Given this list of marker genes CNOT9, PARN, PAN3, PAN2, CNOT4, CNOT2, TUT7, CNOT6, PABPC1, TNKS1BP1, CNOT6L, EIF4A1, EIF4G1, TUT4, CNOT8, EIF4B, PAIP1, CNOT3, CNOT1, CNOT7, EIF4A2, CNOT10, CNOT11, EIF4A3, EIF4E, here is a description of the gene set: Deadenylation of mRNA Human Gene Set: REACTOME_DEADENYLATION_OF_MRNA species: Homo sapiens